Given this list of marker genes Glmn, Trpc4ap, Cul4b, Rbx1, Cop1, Ddb2, Cdkn1b (NCBI Gene Id 12576), Ercc8, Rbx1-ps, Ddb1 (NCBI Gene Id 13194), Cul4a, Arih1, Crbn, Det1, Dtl, here is a description of the gene set: A ubiquitin ligase complex in which a cullin from the Cul4A subfamily and a RING domain protein form the catalytic core; substrate specificity is conferred by an adaptor protein. Mouse Gene Set: GOCC_CUL4A_RING_E3_UBIQUITIN_LIGASE_COMPLEX studied in species Mus musculus